Given this list of marker genes CD247, ELMO1, PAK2, LCK, FYN, HCK, RAC1, DOCK2, here is a description of the gene set: Human Gene Set: REACTOME_NEF_AND_SIGNAL_TRANSDUCTION studied in species Homo sapiens Nef and signal transduction